Given this list of marker genes Tor1a, Per2, Gdnf, Fev, Itgb1, Gpm6b, Syngr3, Flot1, Rab3b, Slc18a1, App, Gfap, Slc17a8, Snca, Nat8l, Arl6ip5, Nos1, Itgb3, Prkn, Drd2, Drd3, here is a description of the gene set: Any process that modulates the frequency, rate or extent of the directed movement of a neurotransmitter into a neuron or glial cell. studied in species Mus musculus Mouse Gene Set: GOBP_REGULATION_OF_NEUROTRANSMITTER_UPTAKE